Given this list of marker genes Tbx5, Gja5, Ehd3, Agt, Nkx2-5, Trpm4, Ank2, Gjd3, Ryr2, Ace2, Tnni3k, Tmem65, here is a description of the gene set: Any process that modulates the frequency, rate or extent of cardiac conduction. species: Mus musculus Mouse Gene Set: GOBP_REGULATION_OF_CARDIAC_CONDUCTION